Given this list of marker genes ATP6V0D1, ATP6V1C2, ATP6V0A2 (ATPase H+ transporting V0 subunit a2), ATP6V1E2, ATP6V1B1, ATP6V0A1, ATP6V1E1, ATP6V1A, ATP6V0A4, ATP6V1B2, ATP6V1G2, ATP6V0E2, TCIRG1, ATP6V1G1, ATP6V0D2, ATP6V0B, ATP6V0C, ATP5F1B, ATP6V1F, ATP6V0E1, ATP6V1G3, ATP6V1H, ATP6V1D, ATP6V1C1, here is a description of the gene set: Human Gene Set: GOMF_ATPASE_COUPLED_ION_TRANSMEMBRANE_TRANSPORTER_ACTIVITY species: Homo sapiens Enables the transfer of an ion from one side of a membrane to the other, driven by the reaction: ATP + H2O = ADP + phosphate.